The following is a description of a gene set: species: Mus musculus Mouse Gene Set: BERENJENO_TRANSFORMED_BY_RHOA_REVERSIBLY_UP We have used microarray technology to identify the transcriptional targets of Rho subfamily guanosine 5'-triphosphate (GTP)ases in NIH3T3 cells. This analysis indicated that murine fibroblasts transformed by these proteins show similar transcriptomal profiles. Functional annotation of the regulated genes indicate that Rho subfamily GTPases target a wide spectrum of functions, although loci encoding proteins linked to proliferation and DNA synthesis/transcription are upregulated preferentially. Rho proteins promote four main networks of interacting proteins nucleated around E2F, c-Jun, c-Myc and p53. Of those, E2F, c-Jun and c-Myc are essential for the maintenance of cell transformation. Inhibition of Rock, one of the main Rho GTPase targets, leads to small changes in the transcriptome of Rho-transformed cells. Rock inhibition decreases c-myc gene expression without affecting the E2F and c-Jun pathways. Loss-of-function studies demonstrate that c-Myc is important for the blockage of cell-contact inhibition rather than for promoting the proliferation of Rho-transformed cells. However, c-Myc overexpression does not bypass the inhibition of cell transformation induced by Rock blockage, indicating that c-Myc is essential, but not sufficient, for Rock-dependent transformation. These results reveal the complexity of the genetic program orchestrated by the Rho subfamily and pinpoint protein networks that mediate different aspects of the malignant phenotype of Rho-transformed cells. Genes up-regulated in NIH3T3 cells (fibroblasts) transformed by expression of contitutively active (Q63L) form of RHOA off plasmid vector; their expression reverted completely after treatment with Y27632, an inhibitor of ROCK proteins. from publication Berenjeno IM, Núñez F, Bustelo XR (PMID 17213802), and this is the list of marker genes: Tnfrsf1b, Sqstm1, Pik3r1, Ly6a, Dap, Gsta4, Ugt1a2, Mgst3, Dnm1, Mt2